Given this list of marker genes FZD4-DT, NIPSNAP2, TAS2R14, PDE4A, RPS3A, ETAA1, EIF3J, NABP1, CNOT6L, LTC4S, ALG13, USP12, LINC02893, CNBD1, FOXN2, ST8SIA3, SLC26A8, IPO7 (importin 7), CNIH1, ETS1, RB1, CFAP97, GSC2, TRAF3IP1, FAIM (NCBI Gene Id 55179), SLC25A16, PATE2, TSPAN5, ZNF217, PGM2, PPP1R15B, RAB10, LINC01783, L3HYPDH, WNT5A, TPR, C6, ONECUT1, SMIM13, SOS2, TP53, AMZ2P1, FAM111A, MARCKS, DNMT3A, VCX2, CDCA2, SPEM1, TMEM263, C1orf198, BAG4, RIOK2, KCMF1, LTV1, ZDHHC2, PHF6, COX19 (cytochrome c oxidase assembly factor COX19), NAALADL2, GPR150, CHCHD3, PHF13, FAM98B, ENTHD1, RLN2, TIMD4, RDH11, FAM217A, EFHC1, PRAM1, SIGLEC11, SLC30A6, REST, LANCL1, MCFD2, CACNA1H, RTN4, SMARCE1, RNF122, SRP9, RALYL, SIGMAR1, GGACT, SLC12A8, ZRANB2-AS1, SMNDC1, BEX4, ABCB7, ALDH1A2 (NCBI Gene Id 8854), TMSB15B-AS1, CHRAC1, DUBR, ZNF572, CACUL1, BET1, CTNNB1, ZNF491, EPB41L2, ARHGEF34P, AKIRIN1, BRMS1L, LEF1-AS1, H1-1, PLD6, RNF144A, SCUBE1, MIR9-2HG, DGCR6L, FAM223B, TOM1L2, NUF2 (NUF2 component of NDC80 kinetochore complex), ISM1, MAPK9, AGO1, UBA6, EXOC5, ARFIP1, MTURN, ZNF663P, TMEM156, WBP1L, TIAM1, USP6NL-AS1 (NCBI Gene Id 439951), TMEM44-AS1, RPL23AP32, HSPA13, CD53, DRAM2, ATP9A (NCBI Gene Id 654090), MDFIC, TOMM20, SH3BP4, FGF7, SRP72, CDH5, C1D, MPZL3, DENND1B (DENN domain containing 1B), SPTSSA, ETNPPL, TAF12, H2BC13, RAB1A, PUS1, CEP97, CCL17, FAM167A (NCBI Gene Id 83648), ZNF17, PROX1-AS1, DPPA4, TCP10L3, ZSCAN5A, LRG1, VWA8-AS1, CCDC24, TTC28, PLPPR5-AS1, HOMER1, GGN, HS3ST3B1 (heparan sulfate-glucosamine 3-sulfotransferase 3B1), METTL21A, SPANXC, CATSPER2, MFSD6, DNAH1, ZC3H4, CALR, GRIK1, ZNF667-AS1, PELI2, PCSK2 (NCBI Gene Id 5126), MYL2, PLAC4, B3GALNT2, ARL4C, FBXO15, DBF4, ZNF204P, SAT1, FLACC1, SKP1, CCDC121, FOLH1B, SIRT4, EID1, KIF5C, RAD23B, ABCC3, SLC35B4, LRRC74B, QTRT2, CCL8, RGS9BP, here is a description of the gene set: from publication Szanto A, Balint BL, Nagy ZS, Barta E, Dezso B, Pap A, Szeles L, Poliska S, Oros M, Evans RM, Barak Y, Schwabe J, Nagy L (PMID 21093321) Genes up-regulated in bone marrow-derived macrophages with STAT6 knockout: control versus treated with rosiglitazone. Human Gene Set: GSE25088_CTRL_VS_ROSIGLITAZONE_STIM_STAT6_KO_MACROPHAGE_UP studied in species Homo sapiens C57Bl/6 wild-type and STAT6 KO mice were used to study PPARg and IL-4 signaling. Bone marrow of 3 mice per group was isolated and differentiated to macrophages with M-CSF (20 ng/ml). 20 ng/ml IL-4 was used to induce alternative macrophage activation and 1 uM Rosiglitazone (RSG) was used to activate PPARg. From each mouse 4 samples were generated: 1. M-CSF, 2. M-CSF+RSG, 3. IL-4 and 4. IL-4+RSG. All compounds were added throughout the whole differentiation process, and frech media was added every other day. Control cells were treated with vehicle (DMSO:ethanol). After 10 days, RNA was isolated and gene expression profiles were analyzed using Mouse Genome 430 2.0 microarrays from Affymetrix.